The following is a description of a gene set: pDC Human Gene Set: HE_LIM_SUN_FETAL_LUNG_C2_PDC_CELL from publication He P, Lim K, Sun D, Pett JP, Jeng Q, Polanski K, Dong Z, Bolt L, Richardson L, Mamanova L, Dabrowska M, Wilbrey-Clark A, Madissoon E, Tuong ZK, Dann E, Suo C, Goh I, Yoshida M, Nikolić MZ, Janes SM, He X, Barker RA, Teichmann SA, Marioni JC, Meyer KB, Rawlins EL (PMID 36493756) species: Homo sapiens, and this is the list of marker genes: OCIAD2, RELL2, GPX7, COBLL1, KIRREL3, ATP13A2, IRF4, ATP2A3, TMEM8B, SPIB, NEK8, SOCS1, CD2AP, KCTD5, IFNLR1, ERN1, MAP1A, TSPAN13, IGLC3, CIB2, COL26A1, NPC1, PCED1B, EPHB1 (EPH receptor B1), LRRC26, CYB561A3, SEL1L3, SMPD3, PTCRA, SLC15A4, SLC2A1, MYBL2 (MYB proto-oncogene like 2), GRAMD1B, STAMBPL1, LINC00513, SLC44A2, SIT1, APP, SEPTIN1, LIME1, LINC00865, IGLC2, RUNX2, PPM1J, NIBAN3, SLC37A1, ADAT3, LTB, LILRA4, TLR9, AHI1, PLVAP, ABHD15, DNASE1L3 (NCBI Gene Id 1776), ADA, SH2D3C, SLA2, ADGRG5, ST6GALNAC4, KPTN, TRAF4, IDH3A, UGCG, IGLL5, DUSP5, PMEPA1, HS3ST1, LY9, TNFRSF17, SGSM3, PAFAH2, CHML, SMC6, RECQL5, PACSIN1, JCHAIN, SLAMF7, TMIGD2, TPM2, A1BG, LINC00996, LAMP5, TMEM63A, PTPRCAP, HS3ST3B1, CLEC4C, ZNF296, TNFRSF21, C12orf75 (NCBI Gene Id 387882), GNG7, AEBP1, CLIC3, MDFIC, CXCR3, CDKN2D, FUZ, TTC24, IFIT2, CDCA7L, SPON2, ULK1, PRMT7, PPP1R14B (protein phosphatase 1 regulatory inhibitor subunit 14B), CDH23, SVIP, BCL11A, EPHA2, IL3RA, LRRC36, MAPKAPK2, TTC39A, CD3E, MZB1, RHEX, CD7, CCDC186, PFKFB2, STRBP, ZDHHC17, BCL7A, ST3GAL2, IGHM, SEMA7A, PRXL2A, MNAT1 (MNAT1 component of CDK activating kinase), SERPINF1, CXXC5, RASD1, CARD11, SLC20A1, TASP1 (taspase 1), PTPRS, SMIM5, SLC7A5, IGKC, SCT, GZMB, DERL3, TCL1A, PARP10, TUBB6, PPM1K, KCNK17, ADAM19, TNNI2, CUX2, ZFAT